The following is a description of a gene set: studied in species Mus musculus Eicosanoid synthesis Mouse Gene Set: WP_EICOSANOID_SYNTHESIS, and this is the list of marker genes: Pla2g2a, Ptges2, Pla2g6, Tbxas1, Ptgds, Ggt1, Ptgs1, Alox5ap, Lta4h (NCBI Gene Id 16993), Alox12, Pnpla8, Ltc4s, Alox5, Ptgs2, Ptges, Dpep1, Alox15, Alox8